Given this list of marker genes IFIH1, OAS1, STING1, CGAS, IRF3, RNASEH2B, RNASEH2C, MAVS, TREX1, RNASET2, RIGI, ADAR, IFNB1 (NCBI Gene Id 3456), RNASEL, RNASEH2A, SAMHD1, here is a description of the gene set: Human Gene Set: WP_PATHWAYS_OF_NUCLEIC_ACID_METABOLISM_AND_INNATE_IMMUNE_SENSING studied in species Homo sapiens Pathways of nucleic acid metabolism and innate immune sensing